The following is a description of a gene set: studied in species Homo sapiens Genes in the cancer module 329. Human Gene Set: MODULE_329, and this is the list of marker genes: LAMA2, FLII, MYL4, FGF2, ACTA1, MYL1, MYH11, MYH3, ACTG2, MYF6, AEBP1 (AE binding protein 1), ADAM12, MYH7, CHRNB1, GJA1, GJA5, PLN, BDKRB2, SGCG, VIPR1, ACTC1, SPEG, CACNG1, HRC, PPP1R12B, CSRP3, MYBPC1, CALD1, FKBP1B, IGF1, ACTA2, MYL7, CASQ2, FHL1, FXYD1, ALDOA, TNNI2, MYOM1, COL6A3, MYOD1, TNNT3, NEB, NOS1 (nitric oxide synthase 1), MYOM2, SSPN, RYR1, EDNRA, KCNH2, SCN5A, CKMT2, CRYAB